The following is a description of a gene set: The series of molecular signals initiated by a ligand binding to a vascular endothelial growth factor receptor (VEGFR) on the surface of the target cell, and ending with the regulation of a downstream cellular process, e.g. transcription. studied in species Homo sapiens Human Gene Set: GOBP_VASCULAR_ENDOTHELIAL_GROWTH_FACTOR_RECEPTOR_SIGNALING_PATHWAY, and this is the list of marker genes: FOXC1, FLT4, VAV2, SLC31A1, VEGFD, EMILIN1, FGF10, VAV1, MMRN1, CADM4, SULF1, CLEC14A, FOXC2, DAB2IP, VTN, HSPB1, MAPKAPK2, ROBO1, HHEX, BCAR1, VEGFA, MMRN2 (multimerin 2), GRB10, EPN2, HIF1AN, ARNT (aryl hydrocarbon receptor nuclear translocator), FGF18, SRC, FZD4, ITGA5, DLL1, MIR10B, XBP1, PRKD1, MIR10A, PAK2 (NCBI Gene Id 9106), MAPKAPK3, PTPN1, HIF1A, FYN, MIR296 (NCBI Gene Id 407022), PDCD6, MT3, AXL, TMEM204, PRKD2, PRKCB, PTK2B, MAPK14, IL1B, FLT1, MIR1224, PGF, ITGB3, HGS, VEGFB, PTK2, KDR, MIR200C (NCBI Gene Id 406985), NRP1, VEGFC, FGF9, NEDD4